The following is a description of a gene set: species: Homo sapiens Human Gene Set: GOBP_REGULATION_OF_GAMMA_DELTA_T_CELL_DIFFERENTIATION Any process that modulates the frequency, rate or extent of gamma-delta T cell differentiation., and this is the list of marker genes: SOX13, LEF1, STAT5B, SYK, TCF7, EGR3 (NCBI Gene Id 1960), STAT5A, PTPRC, NCKAP1L, SOX4, LCK